The following is a description of a gene set: from publication Horikawa K, Martin SW, Pogue SL, Silver K, Peng K, Takatsu K, Goodnow CC (PMID 17420266) IgG cytoplasmic tail interferes with the induction of antigen-response genes Genes down-regulated in B lymphocytes: expressing IgM BCR fusion and untreated versus expressing IgMG BCR fusion and treated by anti-HEL. Human Gene Set: GSE7218_UNSTIM_VS_ANTIGEN_STIM_THROUGH_IGG_BCELL_DN species: Homo sapiens, and this is the list of marker genes: RAP1GAP2, PRPH, LEF1, BLVRB, PSD4, LILRB4, THY1, ATF3, IL2RA, TXNDC17, CD6, APOL6, PROC, PLA2G7, IFNGR1 (interferon gamma receptor 1), ITGB2, RMDN3, SOCS1, RAC2, CXCR6, TREML2, RGS1, GPR171, SH3GLB1, PTGER4, ANKRD55 (NCBI Gene Id 79722), TRAF1, TRDN, GIMAP6, PTPN6, IL18RAP, GEM, GIMAP4, CIMAP1B, CSF2, KLRG1, C19orf12, SERPING1, PDCD1LG2, TNFRSF18, MYOC, USP17L5, PLA2G4C, ACOD1, CD69, SLC43A3, HCAR2, IKZF3, GADD45B, JDP2, HOPX, IL2RB, HERC5, APOD, CASP4, TIGIT, SH2D2A, NLRC5, LAT, SASH3, GNG2, ALDH1A1, LCK, CD53, IL21R, VIL1, DRAM1, STAT4, ZDBF2, AIM2, RASGRP1, IL1RN, ITGB7, PRF1, CHST11, GRIP1, CCR7, CORO2A, IFI44, GPR174, SLAMF7, RHOH, ADAM1A, EPSTI1, UBD, ITK, L1TD1, HAP1, SYTL3, TBX21, PLAAT3, LFNG, PIM1, CASP7, PLAT, CCR8, SHISA5, CLEC4E, RUNX2, NCF4, SV2C, CXCL11, ID1, CORO1A, GZMK, LSP1, KCNJ13, BIN2, UBASH3A (NCBI Gene Id 53347), FLI1, ITGAL (integrin subunit alpha L), SELPLG, NRG1, SRGN, NR4A2, AXL, THEMIS (thymocyte selection associated), RGS16, GPR68, TMSB10, ARHGAP15, H2AC15, CD74, GRAP2, TNFRSF1B, CRIP1, CD2, SMC1B, ZAP70, F2RL2, OAS3, TRPC3 (NCBI Gene Id 7222), CST7, PGLYRP1 (peptidoglycan recognition protein 1), GSTT1, SGMS2, TAPBP, ICOS, DGKA, KCNK5, GADD45G, KLRC1, S100A9, SLPI, IL36G, CCRL2, LPXN, RNF19B, ISG20, CD300LF, IFITM1, CCL3, IRAK3, CHSY1, MYO1G, TNF, SH2B2, CSTB, HAVCR2, ZBTB32, GSDMD, LCN2, NUPR1, CD3D, S100A6, NFKBIE, GADD45A, SEPTIN1 (NCBI Gene Id 1731), KDM4D